The following is a description of a gene set: studied in species Homo sapiens Human Gene Set: GOBP_MEMBRANE_PROTEIN_PROTEOLYSIS The proteolytic cleavage of a transmembrane protein leading to the release of its intracellular or ecto-domains., and this is the list of marker genes: TNFRSF1B, IFNG, RGMA, NRDC, APH1A, PRTN3, FURIN, ADAM19, TIMP4, SPPL2B, IL1B, SPPL2C, GPLD1 (glycosylphosphatidylinositol specific phospholipase D1), LRIG2, IL10, ADAM17, TMPRSS6, ROCK1, BACE2, ADAM9, DAG1, PTPN3, TIMP1, APP, TSPAN5 (tetraspanin 5), TSPAN17 (NCBI Gene Id 89852), APOE, P2RX7, CTSH, TSPAN15, MBTPS2, PRKCQ, RHBDD1, NAPSA, TIMP3, RBMX, SNX33, CWH43, ERAP1, TIMP2, SPPL3, TNF, MMP7 (NCBI Gene Id 4316), PSEN1, TGFB1, SH3D19, ADRA2A, SPPL2A, ADAM8, BACE1, NCSTN, HM13, PARL, PACSIN3, SNX9, ADAM10, AFG3L2, APH1B (aph-1 homolog B, gamma-secretase subunit), CLPP, RET, PSENEN, MBTPS1, MYH9, PSEN2